Given this list of marker genes NR4A1, EMC2, ARF3, CERS2, TOLLIP, SOX5, DCK, LMNB1, RXYLT1, WDHD1, ZNF106, SUB1, NSD1, ZNF503, NPM3, SLC44A2, EXOSC10, WLS, RAD51, CLTB, CCDC93, TUBGCP3 (NCBI Gene Id 10426), CLN8, CRKL, RASA1, HEY1, MLF2, MR1, AP1B1, PKNOX1, TRDMT1, ETNK1, ATXN7L3B, COPZ2, CD37, CTF1, CCNB2, SLC12A4, SMARCD1, NDRG3, ABI1, SCN1A, CDC6, GABPA, NCBP1, DCTN5, HDLBP, CD83, XPR1, COL18A1, FH, SNX6, SLC1A5, NR6A1, SFXN1, SDC1 (syndecan 1), NICOL1, FERMT3, ELOVL6, RHOQ, SLC25A36, FASTKD5, HOXA2, BSG, ST8SIA1, SMIM14, ORMDL1, FPGS, KRR1, STX6, PUM2, NUMA1, PTCD2, TPGS2, WASHC3, RAG2, P2RX6, LPAR1, CAPZA1, XPOT, SFXN2, G3BP2, INPP5A (inositol polyphosphate-5-phosphatase A), IDH3G, ASS1, HIC1, SELENOF, MEF2D, PKP4, REX1BD, COQ9, SNX2, MTHFR, OGA, DNAJC13, PSAT1, PHKA1, SRGAP2, ACAA2, SLC39A7 (NCBI Gene Id 7922), POLDIP2, NDST1, NELFCD, MPP1, ABHD8, PPIH, ZC3H14, RPUSD4, STRADA, MAP3K11, DNAI4, SMC3, LY75, CINP, GPAM, NSMCE4A, ANKFY1, RRAS, SLC39A8, KPNA6, FLOT2, TGFBR1, PTP4A3, MITF, GLRB, SDHD, CSNK1E, PRKCD, FOXO3, IRGM, PDK3, EMG1, LCK, PCCB, CYRIB, CNN2, HDAC7, CAPN2 (NCBI Gene Id 824), PSMD3, SEC62, LIG1, EPHB6, NCOA6, PAM16, EVL, GALNT10, CLIP4, FAM216A, RGCC, CX3CL1, ARMC1, ERH, TRIM21, BCL7C, ZNF282, CUL2, CYP7B1, PLEKHA7, RAB4A, NPNT, RCAN3, EPB41L4B, VPS29, RNASET2, TSPAN12, UBE2H, SRP68 (signal recognition particle 68), SCMH1, CCT2, SIN3B, MPHOSPH9, SLC4A4, WDR81, DIP2B, TXNDC17, BCKDHB, ABCB9 (NCBI Gene Id 23457), PBX3, BNC1, PHC2, MAPK1, ARHGAP9, PBX2, HGSNAT, SKIC8, MRPS31, LIMA1, NNT, POLG, TSPAN9, REXO2, WDR82, COL4A5, MAN2A1, IRS2, BHMT2, CD6, RNF145, PDIA5, here is a description of the gene set: Human Gene Set: GSE27670_BLIMP1_VS_LMP1_TRANSDUCED_GC_BCELL_DN In this study, we have investigated the effect of BLIMP1α on gene expression, cell differentiation and pathogenesis in normal human GC B cells using a non-viral vector based system from publication Vrzalikova K, Vockerodt M, Leonard S, Bell A, Wei W, Schrader A, Wright KL, Kube D, Rowe M, Woodman CB, Murray PG (PMID 21411757) species: Homo sapiens Genes down-regulated in germinal center B lymphocytes over-expressing: PRDM1 versus Epstein-Barr virus protein LMP1.